Given this list of marker genes LDLRAD3, SLC43A2, IRF2BPL, DNAL4, HTRA1, GALNT2, ZMIZ1, SH3BP4, AKR1C3, CCDC40, SOCS6, SPRY1, TESK2, MAP3K2, RCC2, RIN3, GRB2, RALA, DNAJC6, RHBDD3, MIR155HG, TMEM51, UBL7-DT, BTG1, CYP19A1, GPR108, PHC2, IFT22, SAT1, MLPH, FANCI, TMEM144, PTTG1, SSH2, SKP1, ECHDC1, BRPF3 (bromodomain and PHD finger containing 3), S100A10 (NCBI Gene Id 6281), ELL2, TFEB (NCBI Gene Id 7942), PPM1B, RMDN2, SELENOH, NFKBIA, PPT1, PIP4K2C, OR51E1, GPR84, NCOA4, BLMH, HES1, SMAD7, ANXA5, FST, IL18R1, TULP4, NUPR1, SNAI3, LYSET, RHOT1, KTN1, DNAAF4, GABARAPL2 (NCBI Gene Id 90769), PMEPA1, GAL3ST4, GBE1, C15orf62, ABCG1, IFNGR2, KLF10, GPD2, GPR157, CEBPB, PPIF, AZI2, SLC16A6, MTM1, GRN (NCBI Gene Id 2896), TMEM52B, UBXN2B, SLC19A2, CPD, PLXDC2, SPRING1, CEP170, LIMS1, WNT5A, CFAP36, PLAUR, CKLF, ATP6V0E1, DOK3, KLHL29, ADPGK, RNASE4, ARHGEF40, GPRIN3, SLC46A2, FFAR4, USP9X, BIN2, STX6, TGFBR1, LTA4H, SNX10, ISCU, LAIR1, SLC8A1, BLOC1S2, BNC2, PRR15, RNPEPL1, OLR1, CLIP4, NEK6, OLFML3, ITGAV, APIP, P2RY11, GCHFR, ID2, GLUL, VSIG10L, ANOS1, TLE3, KLHL6, ZNF281, APOC2, RNF166, SNTB1, MGST1, SKIL, S100A11, PGM1, PSME4, CELF6, GRB10, TREM1, FAM89A, RFFL, SLC16A10, ELK3 (ETS transcription factor ELK3), PLOD2, TANC2 (tetratricopeptide repeat, ankyrin repeat and coiled-coil containing 2), GON7, RAB18, ARMC8, CHST11 (carbohydrate sulfotransferase 11), MCEMP1, NLRP12, FNDC3B, ANG, LRPAP1, SYS1, TRPT1, KLC2, APBB1IP, SKI, GRINA, ID2B, ARL4A, ID3, RWDD2A, MFGE8, MAPK9, RMDN3, STT3B, PEX19, SERPINE1, GNB4, FURIN, HMGB3, MOAP1 (modulator of apoptosis 1), CCDC9B, ARL5A, RBP4, DUSP1, MMP2, PDLIM7, RASA1, ERGIC1, THEM6, SLCO2B1, SLC31A2, TTC7A, RNFT1, CD58, KCNK13, SLC7A7, LPIN2, ZMYM6, TBC1D16, PGRMC1, JPT1, DLC1, DNASE2, HAMP, FAM120AOS, TYRO3, here is a description of the gene set: Human Gene Set: GSE19198_CTRL_VS_IL21_TREATED_TCELL_1H_DN Genes down-regulated in T cells: control (0h) versus IL21 treatment for 1h. species: Homo sapiens from publication Kwon H, Thierry-Mieg D, Thierry-Mieg J, Kim HP, Oh J, Tunyaplin C, Carotta S, Donovan CE, Goldman ML, Tailor P, Ozato K, Levy DE, Nutt SL, Calame K, Leonard WJ (PMID 20064451) Interleukin-21 (IL-21) is a pleiotropic cytokine that induces expression of transcription factor BLIMP1 (encoded by Prdm1), which regulates plasma cell differentiation and T cell homeostasis. We identified an IL-21 response element downstream of Prdm1 that binds the transcription factors STAT3 and IRF4, which are required for optimal Prdm1 expression. Genome-wide ChIP-Seq mapping of STAT3- and IRF4-binding sites showed that most regions with IL-21-induced STAT3 binding also bound IRF4 in vivo, and furthermore, revealed that the noncanonical TTCnnnTAA GAS motif critical in Prdm1 was broadly used for STAT3 binding. Comparing genome-wide expression array data to binding sites revealed that most IL-21-regulated genes were associated with combined STAT3-IRF4 sites rather than pure STAT3 sites. Correspondingly, ChIP-Seq analysis of Irf4_/_ T cells showed greatly diminished STAT3 binding after IL-21 treatment, and Irf4_/_ mice showed impaired IL- 21-induced Tfh cell differentiation in vivo. These results reveal broad cooperative gene regulation by STAT3 and IRF4.